Given this list of marker genes Alox5ap, Alox12e, Alox12b, Alox12, Alox8, Alox5, Aloxe3, Alox15, Pla2g3, Gpx4 (NCBI Gene Id 625249), Gpx1, here is a description of the gene set: Mouse Gene Set: GOBP_LIPOXYGENASE_PATHWAY The chemical reactions and pathways by which an unsaturated fatty acid (such as arachidonic acid or linolenic acid) is converted to other compounds, and in which the first step is hydroperoxide formation catalyzed by lipoxygenase. species: Mus musculus